The following is a description of a gene set: Reactome Pathway: RHO GTPases activate KTN1 part of: RHO GTPase Effectors electronically inferred by orthology from the curated human pathway This event has been computationally inferred from an event that has been demonstrated in another species.<p>The inference is based on the homology mapping from PANTHER. Briefly, reactions for which all involved PhysicalEntities (in input, output and catalyst) have a mapped orthologue/paralogue (for complexes at least 75% of components must have a mapping) are inferred to the other species. studied in species Mus musculus, and this is the list of marker genes: Klc4, Cdc42, Klc3, Ktn1 (kinectin 1), Kif5b